The following is a description of a gene set: Acute lymphoblastic leukemia studied in species Homo sapiens A form of acute leukemia characterized by excess lympoblasts. Human Gene Set: HP_ACUTE_LYMPHOBLASTIC_LEUKEMIA, and this is the list of marker genes: MSH2, ETV6, BRCA2, TAL2, BAX, IKZF1, PIGL, GFI1, NSD1, TRIP13, GNB1, CHEK2, LZTR1, FLT3, ATM, MDM2, BCR (BCR activator of RhoGEF and GTPase), BUB3, ELANE, NSUN2, NBN, CEP57, DUT, CDKN2A, LIG4, APC2, TP53, TAL1, ABL1, SRP19, BLM, HAX1, BUB1B, BUB1, NUP214, CLPB, TCF3, TCIRG1